Given this list of marker genes CRLS1, TAFAZZIN, DNAJC19, PNPLA8, MECP2, SPATA18, HADHA, PTPMT1, PLA2G6, PHB2, PGS1, LCLAT1, TAMM41, THEM5, here is a description of the gene set: The chemical reactions and pathways involving cardiolipin, 1,3-bis(3-phosphatidyl)glycerol. species: Homo sapiens Human Gene Set: GOBP_CARDIOLIPIN_METABOLIC_PROCESS